Given this list of marker genes CCL4, CCL3, CCL7, CCL2, KLRK1, KLRC4-KLRK1, XCL1, CCL5, here is a description of the gene set: Human Gene Set: GOBP_REGULATION_OF_NATURAL_KILLER_CELL_CHEMOTAXIS studied in species Homo sapiens Any process that modulates the frequency, rate or extent of natural killer cell chemotaxis.